The following is a description of a gene set: Human Gene Set: KEGG_MEDICUS_VARIANT_AMPLIFIED_MYCN_TO_TRANSCRIPTIONAL_ACTIVATION Pathway Definition from KEGG: MYCN* == MAX => (MDM2,PTK2,TP53,BMI1) studied in species Homo sapiens Amplified MYCN to transcriptional activation. Pathway ID: N00131. Pathway type: Variant. Pathway class: nt06240 Transcription., and this is the list of marker genes: PTK2, TP53, MDM2, MYCN, BMI1, MAX